The following is a description of a gene set: studied in species Mus musculus part of: Cobalamin (Cbl, vitamin B12) transport and metabolism Reactome Pathway: Transport of RCbl within the body electronically inferred by orthology from the curated human pathway This event has been computationally inferred from an event that has been demonstrated in another species.<p>The inference is based on the homology mapping from PANTHER. Briefly, reactions for which all involved PhysicalEntities (in input, output and catalyst) have a mapped orthologue/paralogue (for complexes at least 75% of components must have a mapping) are inferred to the other species., and this is the list of marker genes: Abcd4, Tcn2, Gm19410